The following is a description of a gene set: Mouse Gene Set: GOBP_MATING_BEHAVIOR The behavioral interactions between organisms for the purpose of mating, or sexual reproduction resulting in the formation of zygotes. species: Mus musculus, and this is the list of marker genes: Svs3a, Ncoa2, Oxtr, Fuom, P2rx1, App, Abat, Trpc2, Hdac2, Hexb, Oprm1, Slc6a4, Avp, Thra, Mapk8ip2, Klk14, Ednrb, Hdac4, Ar, P2ry2, Ddo, Serpine2, Acvr2a, Vmn2r116, Grin1, Pten, Aplp2, Ube2q1, Tgm4, Tacr1, Nlgn4l, Thrb, Vip, P2ry1, Ppp1r9b, Pgr, Cyp11a1, Shh, Avpr1a, Th, Esp1, Nhlh2, Ncoa1, Taar5, Ppp1r1b, Grn, Cnr1, Oxt, Drd5, Ada, Drd4, Esp22, Dmrta1, Drd1